Given this list of marker genes APOA2, POR, POC5, L2HGDH, GUK1, LZIC, AFP, RER1 (NCBI Gene Id 11079), AKR1A1, CSTF1, UTP25, ORC4, MMUT, LIPT2, THOC1, RAD54L2, ZC3H8, FOCAD, CCN6, HMOX2, TBL1X, UGP2, KYAT3, ANAPC5, ADRA2C, TWNK, VMP1, SUPT3H, TTC9C, OVCA2, PAGR1 (NCBI Gene Id 79447), WDR3, BTAF1, ZNF207, CUL5, STX6, CCNC, ASH2L, SOCS2, ADISSP, CENPO, ENKD1, PIGG, OGFR, RBBP9, NOL12 (NCBI Gene Id 79159), JRK, TANGO6, GPT2, SMDT1, POLD3, PLAAT5, GCA, CSE1L, THOC7, SDHC, MRPL32, PGPEP1, NOP14, DPAGT1, YBX1, SNUPN, GALE, PPRC1, COPS2, B3GALT4 (NCBI Gene Id 87866), PDIA6, AIMP1, ACSL5, PITHD1, ACY1, TMX1, ATP5MF (NCBI Gene Id 9551), SLAMF7, EIF3G, MRNIP, MAP3K20, SENP1, EXOG, ARFIP2, EXOSC5, CPSF4, PIGY, MTFR2, MRPS9, MAT2A, SNX1, PSME4, FBXO42 (NCBI Gene Id 54455), SHISA9, CYP21A1P, TSSC4, MAP2K2, ALG5, SAMHD1, PUS10, STXBP1, AP5B1, CENPN, POGK, RBSN, NIT1, RBIS, RBM15B, SRP54, TAF12, ROMO1, PTBP1, GLRX3, EPRS1, DSN1, HTT, MAP4K1, DARS2, NOC2L, ACTR6, ZNF764, NSFL1C, RAB35, TMED1, GTF2F2, PLAGL2, SCOC, BMS1, PDE4DIP, THOC5, PUS3 (pseudouridine synthase 3), SETDB1, ZC3H18, BBS5, PDK3, ZNHIT2, PTRH1, G2E3, DNAJC8, MTMR4, RAB29, TTC4, RBL1, TRIM14, BZW2, MRPS5, SIKE1, TNFAIP8L1, FASTKD2 (FAST kinase domains 2), UBE2E1, UQCRC2, DARS1, EIF5B, TEX15, TYSND1, VPS26C, HNRNPA3, NFIL3, RAB34, NUDC, BSN, MRPS25, PIN4, ACADS, SDR39U1, CAD, SIGMAR1 (sigma non-opioid intracellular receptor 1), TRMU, NRK, COX19, ARV1, EME1, MTG1, SMN1, SNHG6, SRP19, TXNL1, NOB1, RNASEH2C (ribonuclease H2 subunit C), ANAPC4, BCL2L13, OXCT1, RIOK2, STAU2, UBXN8, DMAC1, ATP5F1D, C4orf46, RAD51B, LSM1, WDR74, DANCR, PC, MALSU1, GLMN, MOBP, LETM1, COX17, COX18, EFCAB14, CIAO2A, EED, MRPS24 (NCBI Gene Id 64951), here is a description of the gene set: The genome of vertebrates contains endogenous retroviruses (ERVs) that have resulted from ancestral infections by exogenous retroviruses. ERVs are germline encoded, transmitted in a Mendelian fashion and account for about 8% of the human and 9.9% of the murine genome, respectively1, 2. By spontaneous activation and reintegration ERVs may cause insertional mutagenesis and thus participate in the process of malignant transformation or progression of tumor growth3, 4. However, if the innate immune system is able to recognize and control ERVs has not yet been elucidated. Here we report that, in vitro, nucleic-acid sensing TLRs on dendritic cells are activated by retroviral RNA and DNA from infected cells in vitro. Infection of TLR competent wild type mice with murine leukemia virus (MuLV)-like ERV isolates results in non-canonical gene upregulation, independent of type I IFN. In vivo, TLR3, -7 and -9 triple deficient mice (TLR379-/-) and mice with non functional TLR3, 7 and 9 signaling due to a mutation in UNC93B develop spontaneous ERV-induced viremia. More importantly, in TLR379-/- mice ERV-induced viremia correlates with acute T cell lymphoblastic leukemia (T-ALL). Multiple independent TLR379-/- T cell leukemia lines produce infectious MuLV of endogenous origin. These cell lines display de novo retroviral integration into the Nup214 or Notch1 gene locus leading to gene dysregulation that is reminiscent of aberrant Nup214 and Notch1 expression in human T-ALLs5. Overall, our results demonstrate that in addition to their role in innate immune defense against exogenous pathogens, TLR3,-7, and -9 may be essential for the control of endogenous retroviral mediated T-cell lymphomagenesis. Human Gene Set: GSE24671_BAKIMULC_VS_SENDAI_VIRUS_INFECTED_MOUSE_SPLENOCYTES_DN studied in species Homo sapiens Genes down-regulated in splenocytes with viral infection: Baki-1 MuLV versus Sendai. from publication Yu P, Lübben W, Slomka H, Gebler J, Konert M, Cai C, Neubrandt L, Prazeres da Costa O, Paul S, Dehnert S, Döhne K, Thanisch M, Storsberg S, Wiegand L, Kaufmann A, Nain M, Quintanilla-Martinez L, Bettio S, Schnierle B, Kolesnikova L, Becker S, Schnare M, Bauer S (PMID 23142781)